The following is a description of a gene set: species: Homo sapiens Human Gene Set: GOBP_PROTEIN_O_LINKED_FUCOSYLATION The process of transferring a fucosyl group to a serine or threonine residues in a protein acceptor molecule, to form an O-linked protein-sugar linkage., and this is the list of marker genes: SLC35C2, B3GLCT, POFUT2, POFUT1, FUT10, FUT11